Given this list of marker genes RUNX2, IHH, GLI2 (GLI family zinc finger 2), CBFB, HDAC4, here is a description of the gene set: part of: RUNX2 regulates bone development Reactome Pathway: RUNX2 regulates chondrocyte maturation studied in species Homo sapiens In addition to regulating osteoblast differentiation, RUNX2 regulates skeletal development by regulating maturation of chondrocytes. Chondrocyte maturation happens during the process of endochondral ossification. Expression of the parathyroid hormone receptor (PTHR1) and Indian hedgehog (IHH) are hallmarks of chondrocyte maturation. Mice that are double knockouts for Runx2 and Runx3 show a complete absence of chondrocyte maturation and, hence, aberrant limb growth. Based on mouse studies, RUNX2 directly regulates transcription of the IHH gene. RUNX2 binding sites in the IHH gene promoter are conserved in humans. Also based on mouse studies, RUNX2 positively regulates transcription of NELL1 (neural EGFL-like 1), a key functional mediator of chondrogenesis, but direct binding of RUNX2 to the NELL1 gene locus has not been demonstrated. Runx2 binding sites exist in the enhancer of the mouse Col10a1 gene, encoding type X collagen, a marker of hypertrophic chondrocytes, which is critical for endochondral bone formation. While Runx2 binding is required, it is not sufficient to trigger Col10a1 transcription.